Given this list of marker genes NDRG1, MESP2, EGR2, ERCC1, SLC16A2, PMM2, FBN1, TRAPPC2, DLL3, RPS6KA3, COG1, AIFM1 (NCBI Gene Id 9131), NAA10, FHL1, COL1A2, CLP1, TGFB3, GNPTAB, FUT8, TCTN3, DVL1, MAP2K1, FKTN, WDR45B, RAB3GAP1 (NCBI Gene Id 338380), MYO9A, TPM2, PIEZO2, SON, MMP2, SLC5A7, ATRX, MESD, MGAT2, COL13A1, DNA2, CRLF1, IKBKG, CDH11, BCOR, BMP1, MEG3, ACTB, CRELD1, CHST3, COL2A1, PLOD1, TMEM147, ALDH18A1, GDAP1, TMEM165 (transmembrane protein 165), CBS, CFL2, NEMF (nuclear export mediator factor), RECQL4, GZF1, HSPG2, UBA1, ZMYM3, MLXIPL, HRAS, NKX3-2, CTDP1, ARSB, ITGA7, ATG7, SETBP1, SRCAP, NDUFS3, SLC1A2, LAMA2, SYNE1, AGRN, RBM28, PTPN11, MYL2, ATP6V0A2 (NCBI Gene Id 7854), MAPT, MTTP, TTI2, SNX14, POMT1, DSTYK, COL12A1, HTRA1, MVK, FBN2, RYR1, PRX, SYT2, LHX3, AKT1, RAB18, HACD1, ELN, BRAF, ERCC6, NEPRO, TPM3, MAP3K20, PEX7, ARID2, AEBP1, NSDHL, SLC10A7, TUBB4A, PPP1R15B, SURF1, TRPV4, ACTA1, NFIX, VAMP1, ATP6V1E1, MEGF8, SBF2 (SET binding factor 2), ATP6V1A, CHAT, TOR1A, CCN6, DLK1, SH3PXD2B, ATAD1, JPH1, B4GALT7, WDR11, TONSL, NOTCH2, DNMT3A, NUP107, CRPPA, KCNA1, PMP22, NF1, HGSNAT, PPP1R12A, SPART, KY, SLC18A3, H1-4, RSPRY1, NRAS, POP1, RAB23, ZMPSTE24, TRMT10A, FARS2, EBP, EXTL3, SLC39A13, SNAP25, GORAB, HMGB3, POLR3A, SPG11, TNNT1, KRAS, CHST14, B3GALT6, AIMP1, DSE, PAPSS2, ACP5, SMS, NONO, RTL1, LMNA, PTCH1, GLS, FKBP14, JAG1, PNKP, SLC52A2 (NCBI Gene Id 79581), ERCC2, FKBP10, KIF22, TELO2, STAC3, MRPS34, AIMP2, SLC25A1, COL6A3 (collagen type VI alpha 3 chain), TUBB3, CLIC2, MPZ, SLC26A2, MYH3, UBAP2L, FLNA, SOX9, FKRP, SLITRK2, SPARC, MECP2, HERC1, LRP5, SELENON, here is a description of the gene set: An abnormal curvature of the spine in both a coronal (lateral) and sagittal (back-to-front) plane. Kyphoscoliosis Human Gene Set: HP_KYPHOSCOLIOSIS studied in species Homo sapiens